Given this list of marker genes Zcchc9, Penk, Plscr1, Klf4, Lrmda, Sgms2, Slc6a6, Olfml2b, Clvs1, Cdc42ep1, Ly6c1 (lymphocyte antigen 6 family member C1), Cp, Sult1a1, Gadd45a, Nkx2-5, Tbx5, Enpp1, Thbd, Add3, Dock5, Nfe2l2, Cyp1b1, Asah1, Tspan5, Ank, Omd, Oat, Sostdc1, Ptk7, Fmo1, Tsc22d3, Hebp2, Cystm1, Leprot, Abcd4 (ATP-binding cassette, sub-family D member 4), Selenop, Mgp, 1700126A01Rik, Gli1, Vmn1r58, Dspp, Akap12, Cfhr1, H19, Pi16, Tmem140, Bzw2, Pola1, Akap4, Apod, Filip1l, Snx18, Fen1, Fbn1, Ramp2, Serpinc1, Rora, Tek, Ngly1, Alx4, Gpcpd1, Klra2, Ptch1, Mfap3l (microfibrillar-associated protein 3-like), Abca3, Clec3b, Grb14, ENSMUSG00000143536, Zfp36l1, Pltp, Akr1c14, Spry1, Dph6, Rp9, Pomc, Plac8, Inmt, Ftl1, Cmpk2, Arhgef10, Igfbp3, Mr1, Igfbp4, Rpl29, Pramel13, Bmp5, Hes1, Klb, Tgtp1, Smoc2, Slc12a7, Nid1, Nr3c1, Igf1r, Ube2j1, Flt4, Inhca, Slc48a1, Twist2, Mustn1, Ephx1, Map3k1, Igfbp7, Slc27a3, Ifi27l2a, Trim10, Fbn2, Ccn2, Klf10, Bdnf, Dcn, Pmp22, Sin3a, Foxd1, Gstz1, Nr4a1, Dusp1, Plpp3, Gpc4, Rassf3, Gpr155, Mknk2, Ncoa6, Amh, Paics, Rassf8, Dscc1, Dnase2b, Naa50, Slc35e3, Nog, Hhip, Klf9 (NCBI Gene Id 70273), Bglap, here is a description of the gene set: species: Mus musculus Aberrant regulation of signalling mechanisms that normally orchestrate embryonic development, such as the Hedgehog, Wnt and Notch pathways, is a common feature of tumorigenesis. In order to better understand the neoplastic events mediated by Hedgehog signalling, we identified over genes regulated by Sonic Hedgehog in multipotent mesodermal cells. Widespread crosstalk with other developmental signalling pathways is evident, suggesting a complex network of interactions that challenges the often over-simplistic representation of these pathways as simple linear entities. Hes1, a principal effector of the Notch pathway, was found to be a target of Sonic Hedgehog in both C3H/10T1/2 mesodermal and MNS70 neural cells. Desert Hedgehog also elicited a strong Hes1 response. While Smoothened function was found necessary for upregulation of Hes1 in response to Sonic Hedgehog, the mechanism does not require gamma-secretase-mediated cleavage of Notch receptors, and appears to involve transcription factors other than RBP-Jkappa. Thus, we have defined a novel mechanism for Hes1 regulation in stem-like cells that is independent of canonical Notch signalling. Mouse Gene Set: INGRAM_SHH_TARGETS_UP Genes up-regulated in 10T1/2 cells (multipotent mesoderma) by expression of SHH. from publication Ingram WJ, McCue KI, Tran TH, Hallahan AR, Wainwright BJ (PMID 17873912)